The following is a description of a gene set: Mouse Gene Set: GOMF_MOLECULAR_ADAPTOR_ACTIVITY The binding activity of a molecule that brings together two or more molecules through a selective, non-covalent, often stoichiometric interaction, permitting those molecules to function in a coordinated way. species: Mus musculus, and this is the list of marker genes: Shank3, Pramel39-ps, Crtc3, Klhl28, Sla2, Smyd1, Pus1, Stx17, Gosr2, Nanog, Ccdc134, Parp14, Baz2a, Zfp653, Klhl7, Msl3, Med29, Fxr1, Taf1, Ppargc1b, Cdh5, Pramel48, Cul2, Insm2, Cstpp1, Setd3, Cpt1a, Ubqln2, Trim30a, Glyr1, Slc30a9, Golph3, Irs2, Frmd4a, Fbxo42, Ccdc38, Dmap1, mt-Tw, Ppp2r2a, Irak1bp1, Msi1, Cited2, Med15, Vamp1, Ankrd13a, Rraga, Strn3, Atg16l1, Sdr16c5, Eef1a1, Edf1, Pramel56, Camta1 (NCBI Gene Id 75679), Rpa1, Kctd1, Tob2, Ticam1, Lpxn, Zfp541, Daw1, Hipk2, Wipi1, Yap1, Dyrk1a, Tle4, Faf2, mt-Tm, Mms19, Itsn2 (intersectin 2), Klhl11, Ddx1, Appbp2, Racgap1, Kbtbd6, Cux1, Spi1, Cbx7, Med12, Skp2, Pramel30, Sh3bgrl, Spata18, Stap1, Rap2c, Pramel50, Alg14, Trim32, Nme2, Actn3, Klhl8, Lpin1, Ing4, Nlrp4b (NLR family, pyrin domain containing 4B), Sppl2c, Fmr1, Dvl2, Gsdmd, Nsd1, Itsn1, Magi2, Trim13, Rragd, Oog1, Septin14, Foxp3 (forkhead box P3), Mrps36, Trim15, Trim8, mt-Ta, Csnk2b, Med6, Bin1, Cbx2, Ttll12, Bank1, Pramel33, Trim30d, Mki67, Trim30c, Ripk1, Gas2l2, Phf24, Stx1b, Fbxo11, Prima1, Tox3, Fbxo3, Syne2, Slmap, Pramel55, Aip, Uimc1, Tyrobp, Ncoa1, Hdac5, Ercc2, Stat3, Aph1b, Dctn1, Herpud1, Tcf4, Ddx20, Smad7, Hnrnpa2b1, Klhl4, Akap9, H2ax, Kdm1a, Rbfox2, Rybp, Snca (synuclein, alpha), Ncbp1, Septin8 (NCBI Gene Id 20362), Wwc1 (WW, C2 and coiled-coil domain containing 1), Bicd2, Shc1, Akap1, Cbfb, mt-Ts1, Retreg1, Pias2, Ube2l3, Cacybp, Bclaf3, Nipsnap1, Suv39h2, Mark4 (NCBI Gene Id 97378), Tardbp, Dtx3l (NCBI Gene Id 209200), Mier1 (MEIR1 treanscription regulator), Cul3 (cullin 3), Pa2g4, Kbtbd8, Pml, Camta2, Erg28, Iqcb1, Ecpas, Gm3604, Tab2, Pprc1, Sfr1, Ccar1, Fadd, Supt7l, Jchain, Trib3, Tbl1xr1, Ifi204, Ppp1r3c, Prmt2, Zfp1005, Nlrp4e, Fem1al, Hipk1, Tpr, Map2k2 (mitogen-activated protein kinase kinase 2), Usp15, Grb2, Dlgap2, Shb, Sh2d1b1, Psmg2, Mybbp1a, Pramel17, Pramel27, Akap6, Hspa1a, Rere, Anapc7, Vps18, Rab11fip3, Jmy, mt-Tv, Glipr1l1, Tada3, Hcfc2, Phf2, Rad54l2, Hdac4, Nbn, Nupr1, Ap1s2, Tns3, Stx1a, Paxx, Runx1t1, Polk, Kdm5b, Bclaf1, Spin1, Nlrp4c, Hdac1, Pramel47, mt-Ty, Dlgap3, Mical3, Sin3a, Bmal1, Trim12c, Muc1, Men1, Atxn7l3, Golph3l, Morc3, Ager, Hmgb2, Sh2b2, Ccdc124, Brd8, Tdg, Tollip, Pglyrp1, Ythdc2, Trp53, Cdc20, Fcrl2 (Fc receptor like 2), Gab2, mt-Ts2, Sh2d2a, Get1, Klhdc1, Bcl3, Ap1s1, Vamp2, N4bp2l2, Hras, Sap30, Pih1d1, Cebpz, Lpin2, Pef1, Ahdc1, Itga2b, Atg2b, Zzz3, Scimp, Pnkp, Basp1, Btrc, Nolc1, Ctnnb1, mt-Tq, Grb10, Fbxl2, Sfmbt2, Rbp2, Cited4, Sfmbt1, Carm1, Taf12, Gphn, Cdyl2, mt-Tt, Sirt6, Taf7, Kat8 (K(lysine) acetyltransferase 8), Smarcb1, Mrtfb (myocardin related transcription factor B), Sec22b (SEC22 homolog B, vesicle trafficking protein), Fbxw8, Alyreffm5, Ikbkg, Irgm2, Kat6b, Mapk8ip3, Pramel43, Trp53bp1, Myh14, Spen, Keap1, Zfp451, Atp1b2, Arf6, Ap2m1 (NCBI Gene Id 11773), Zfp950, Mlph, Cbfa2t3, Rack1, Wdr59, Ruvbl1 (RuvB-like AAA ATPase 1), Phf10, Slc35d3, Frey1, Notch1, Spaca6, Nkx2-1, Pramex1, Pias4, Dab1, mt-Td, Scrib, Prkaa2, Sarm1, mt-Tn, Brd7, Acss2, Cyren, Ar (androgen receptor), Zfp747l1, Prpf31, Steep1, Exoc7, Smarca2, Zbtb32, Phb1, Pdzd11, Kctd15, Myt1l, Bud31, Fem1c, Irf2bp1, Ivns1abp, Btaf1, Gfi1, Tgfb1i1, Nrg1, Ptpn14, Stx8 (syntaxin 8), Cmtm2a, Taf15, Septin10, Syt1, Vhl, Aimp2, Pclaf, Bcl9, Tada1, Rbbp8, Col4a4, Hnrnpc, Pex6, Kat7, Trim24, Det1, Hdac9, Ap2a2, Trim21 (tripartite motif-containing 21), Rragc, Nelfa, Strn4, Dab2ip, Cdk5rap3, Actn2, Vamp3, Arrb2, Pdcd6, Epb41l3, Cul5, Iqgap1, Hpf1, Nr0b2, Rapsn, Actn1, Ewsr1 (NCBI Gene Id 14030), Sgta, Trip4, Gatad2a, Pramel45, Med26 (NCBI Gene Id 70625), Brd3, Cideb, Hax1, Stx2, Serinc1, Klhl6, Ythdc1, Oog4, Ldlr, Mta1, Cav1, Rbm33, Cul4a, Kdm4a, Ankrd9, Septin2, Bnip1, Med13l, Kat5 (NCBI Gene Id 81601), Mta2, Wbp2nl, Rictor, Pramel21, Insm1, Stxbp1, Hif1an, Klhl12, Dcc, Pcbp2, Ddx17, Ppp2r3a, Mapkap1, Trim12a, Irf2bpl, Gab1, Zmynd8, Nipbl, Rnf20, Id3, Cbfa2t2, Ripk2, Lin28a, Ybx1, Chm, Zfpm1, Ston2 (stonin 2), Sra1, Ilk, Zfpm2, Zfp764l1, Tdrd3, Peli2, Pramel44, Rapgef4, Abi3, Parp10, Alyref2, Rb1, C1d, Crym, Tle6, Ascc1, Traf5, Bhlhe41, Apbb2, Pramel31, Yeats2, Gan (NCBI Gene Id 209239), Noc2l, Traf2, Scai, Fem1a, Bicd1, Tchh, Id2, Ppp4r2, Pramel12, Paqr3, Hmga1, Pramel20, Maged1, Pramel22, Med7, Gnb3, Tada2a, Topbp1, Vim, Sorbs1, Disc1, Chd1l, Lpin3, Alyreffm9, Pramel15, Chd4, mt-Tg, Ippk, Tle1, Homer2, Vgll2, Tbc1d31, Lgals3, Klhl5, Med16, Vti1a, Vcl, Myh9, Tjp2, Jag1, Ski, Kdm3b, Tirap, Gm14443, Klhl25, Dnajb1, Pramel5, Khdrbs1, Mid2, mt-Te, Ksr1, Crtc1, Rufy1, Atf7ip, Mapk8ip1, Ncoa6, Ltbp1, Tle2, Arid5b, Parp9, Prpf6, Mtdh, Taf9, Tcerg1, Zmynd11, Gm13040, Nefh, Crk, Pkn1, Pex26 (peroxisomal biogenesis factor 26), Napb, Eloc, Grb14, Bcl2, Zfp598, Thrap3, Synpo2 (NCBI Gene Id 99735), Col1a2, Mis18a, Sh3rf1, Pcnt, Sun5, Npat, Gnb5, Ctbp2, Syne3, Pramel11, Zfp976, Ddx4, Klhl17, Ifi27l2b, Fgf2, Jade1, Zmiz2, Gabarapl1, Dvl3, Supt3, Mlst8, Zcchc12, Pold3, Lamtor1, Cops2, G3bp2, Nck2, Nck1, Retreg2, Telo2, Fzr1, Hmga2, Ap1m1, Cbx5, Aph1c, Septin5, Igf2bp2, Pcbd1, Ap4e1, Dnajc2, Mier3, Hip1, Midn, Ajuba, Psip1, Dot1l, Stap2, D1Pas1, Fbxo38, Prkn, Ksr2, mt-Tp, Smarca4, Nr3c1, Med12l, Fbxo7, Rcor3, Actn4, Sgtb, Flywch1, Klhl23, Utf1, Cnot1, Tcp10a, Sun2, Pramel49, Pramel14, Brca1, Ruvbl2, Atp1b1, Fnta, Nup153, Nlrp6, Cib1, Arglu1, Liat1, Prkcb, Mdc1, Trim17, Jund, Npm1, Dcaf12, Atg2a, Pias1, Psmc3ip, Zmynd10, G3bp1, Septin11, Sap30l, Klhdc10, Nipsnap2, Hr, Lamp2, Alyreffm8, Zdhhc11, Tcf20, Cidec, Trdn (NCBI Gene Id 76757), Dtl, Tab1, Nab2, Fam81a, Ets1, Fbxw7, Fga, Map2k1, Tax1bp1, Dok2 (docking protein 2), Ddrgk1, Ddx5, Psmg3, Sh2b1, Stx5a, Fscn2, Pramel25, Lmcd1, Smarcd1, Sgk3, Pramel40, Pramel51, Kir3dl1, Sh2d3c, mt-Ti, Capn3, Med8, Dgcr8, Pramel60, Snap47, Pramel19, Letmd1, Traf3ip3, Septin7, Mlip, Cul7, Gps2, Alyreffm11, Med1, Kmt5a, Nfatc2, Jup, mt-Tc, Tfap2a, Rgs14, Lamtor4, Ythdf2, Vps11, Ywhae, Elk1, Nrip1, Uri1, Ccnt1, Tacc1, Mob4, Ehd4, Med24, Med14, Cep63, Zfp1007 (NCBI Gene Id 77200), Stx19, Tnrc6a, Mpp7, Dcaf1, Klhl35, Rbm14, Lmo1, Plcb3, Ldb2, Pramel61, Ythdf3, Kat2b, Ap1s3, Bcor, Nmnat2 (NCBI Gene Id 98444), Dhx9, Apbb1, Niban2, Yaf2, Tcp10b, Mamstr, Smdt1, Cdc42se2, Klhdc2, Adam10, Rbx1, Ccnd1, Kbtbd3, Wnt3a, Mysm1, Calcoco1, Klhl41, Psmg1, Pou2af2, Pex14, Pmf1, Prmt5, Pacsin2, Cys1, Tcerg1l, Med19, Nucks1, Spocd1, Stx16, Sap18, Anapc1, Wnt4, Elane, Hdgf, Asb11, Abi2, Ncoa7, Maml2, Ifnar1, Ssbp3, Trim28, Fan1, Ep300, Baiap2 (brain-specific angiogenesis inhibitor 1-associated protein 2), Dlg1, Cgas, Alyreffm4, Alyref, Pdhx, Faap20, Ing2, Klhdc3, Nlrp4f, Spag4, Paqr4, Gas2l1, Ddit3, Med11, Dlgap4, Fbxl4, Stx3, Jarid2, Ctcf, Tgfbr2, Bcl11a, Vcp, Tpx2, mt-Tf, Rhno1, Hspa8, Kmt2d, Septin1, Sh2b3 (NCBI Gene Id 16923), Pdlim1, Med20, Ezh2, Shank1, Nfkbiz, Cops5, Caprin1, Mak, Draxin, Bnip3, Cdyl, Pramel34, Frs3, Pkp2, Fbxw11, Sike1, Klhl30, Dnajb2, Fscn1, Pramel36 (PRAME like 36), Fiz1, Stx18, Bend6, Fbxo4, Becn1, Dhrs7b, A1cf, Ddx54, Rbx1-ps, Klhl18, Smarcd2, Rb1cc1, Aim2, Nherf1, Cenpj, Zxdc, Ifi27l2a, Tomm70a, Gm45871, Pramel26, Pias3, Kir3dl2, Traf3, Akap13, Napa, Pramel23, Tcf25, Ddx3x, Akirin1, Mideas, Pramel1 (PRAME like 1), Arid5a, Ccin, Ppargc1a, Pramel35, Igf2bp1, Snap91, Hcst, Ezh1, Klhl21, Sod3, Lbr, Fbxo45, Ap1g2, Asxl1, Arrb1, Jmjd1c, Pramel18, Gosr1, Sharpin, Tcp10c, Phf12, Ndc80, Igtp, Mecp2, Cradd, Klhl15, Birc2, Zfp764, Ncoa3, Nlrp4a, Sh3kbp1, Trex2, Klhl20, Htatsf1, Irgq, Tonsl, Psmd4, Nlrp1a, Elob, Gon4l, Irak2, Pptc7, Klhl24, Mphosph8, Ank2, Pde4dip, Hsh2d, Pramel28, Trim38, Usp21, Wnk1, Alyreffm1, Otud4, Ykt6, Chchd3, Kctd17, Zfp366, Setd5, Med17, Nkd2, Cnot9 (NCBI Gene Id 98400), Trim27, Bet1l, Arpc4, Pramel7, Trim55, Fscn3, Kras, Dcaf6, Usp16, Alyreffm3 (NCBI Gene Id 435615), Trim5, Dusp19, Iscu, Ap2a1, mt-Tk, Nefl, Nab1, Lamtor3, Tmf1 (TATA element modulatory factor 1), Thap7, Crtc2, Tsg101, Micall1, Zswim8 (NCBI Gene Id 71906), Stx11, Zfp433, Ston1, Ifi27, Brd1, Pex1, Sub1 (NCBI Gene Id 20024), Eny2, Stx7, Tapbp, Pkm, mt-Tl2, Gm14399, Mrtfa, Rxrb (retinoid X receptor beta), Ncstn, Pramel6, Col4a2, Vti1b, Cnksr1, Cox7a2l, Ctbp1, Rxrg, Igf2bp3, Fhl3, Fis1, Hnrnpu, Pcmtd1, Smarcd3, Ap1g1, E2f1, Tank, Gnb1, Vapa, Ppp2r2d, Lmo2, Kbtbd12, Usp18, Med4, Ankrd13b, Akirin2, Strip1, Cntln, Klhl1, Axin2, Mta3, Napg, Gm14412, Supt20, Pramel13, Fus, Sash1, Tbl1x, Rims2, Irf2bp2, Cnot6, Emilin1, Bet1, Zic3, Zcwpw1, Med13, Dpf2, Mier2, Med22, Trim14, Ldb1, Nsmaf, Drap1, Cd274, Ube2z, Spsb3, Arhgap26, Zfp442, Gmnn (geminin), Brd4, Ark2n, mt-Th, Pramel57, Cnot7, Mapk8ip2, Wdr77, Nr0b1, Akap12, Arrdc4, Oog2, Uxt, Cul1, Gas6, Irf4, Bbs4, Gab3, Brdt, Pramel29, Use1, Eid2, Med27, Snap29, Acp3 (acid phosphatase 3), Alkbh5, Hip1r (NCBI Gene Id 29816), Sertad2, Trerf1, Snw1, Septin3, Kdm2a, Zzef1, Med10, Dlgap1, Kmt2c, Asb1, Map3k10, Zfp354b, Surf6, Fkbp5, Septin4, Arl2bp, Dzip1, Arid3a, Kbtbd2, Ldlrap1, Hsbp1l1, Tial1, C1qbp, Pou2af1 (NCBI Gene Id 18985), Tle5, Hmgb1, Qki, Gm32687, Ipp, Phf8, Nufip1, Sun1, Poldip2, Amfr, Gnb4, Tab3 (TGF-beta activated kinase 1/MAP3K7 binding protein 3), Dab2, H2az2, Alyreffm6, Tradd, Daxx, Id4, Cav2, Per2, Trim30b, Nup98, Eno1b, Tut1, Chd5, Phf13, Pramel41, Ap1m2, Pramel59, Rcor2, Mllt3, Cdca4, Saysd1, Trim62, Hcls1, Fbxo9, Tnnt2, Lat, Stx4a, Pbxip1, Prnp, Park7, Crkl, Insc, Hdac7, Trim6, Ythdf1, Alyreffm10, Gigyf2, Nmnat1, Oog3, Kdm5a, Pwp1, Hcfc1, Wtip, Nlrp12, Lox, Retreg3, Trim37, Pramel46, mt-Tr, Hsbp1, Lamtor5, Ptpn11, Septin9, Srsf3, Sh2d1a, Sertad1, Wwtr1, Limd1, Ankrd1, Septin6, Stx12, Pramel32, Kdm4c, Frs2, Prdm8, Socs7, Ap2s1, Irgm1, Hcn2, Aph1a, Ofd1, Bloc1s6, Atp1b3, Snap23, Klf4, Rnf169, Socs6, Btg2, Apbb3, Phf14, Setd4, Klhl2, Nlrp3, Blnk, Rad17, Abi1, Tsc22d1, Myocd, Pcm1, Kdm7a, Pramel16, Eno1, Pramel24, Sqstm1, Eid1, Kmt2e, Taf6, Wwox, Card9, Zxdb, Nup62, Lmo3 (LIM domain only 3), Apex1, Klhl40, Hdac3, Rcor1, Pramel54, Pramel37, Pramel53, Vapb, Hmga1b, Med21, Med31, Mcur1, Trim11, Ncor1, Lmo4 (LIM domain only 4), Lin7b, Lcor, Rptor, Rbm47, Sp1, Spag9, Ncoa2, Map1a, Ss18, Trabd, Sun3, Klhl38, Stk38, Lin7a, Socs2, Homer1, Ndc1, Vamp9, Tada2b, Nmd3, Id1, Golga5, Trim31, Msl2, Asah1 (NCBI Gene Id 67617), Spsb4, Jazf1, Tle3 (NCBI Gene Id 70332), Spsb2, Klhl10, Irs1, Lin7c, Trim52, Wdr45b (NCBI Gene Id 66840), Mtmr4, Alyreffm7, Trpc4ap, Piwil4, Lrrk2, Dyrk1b, Zfp997, Ticam2, Traf4, Wdr45, Fhl2, Nherf4, Sin3b, Zc3h18, Bmyc, Ddb1, Map2k4, Dcaf13, Pdzk1, Pramel38, Dhx16, Epc1, Tcap, Cdkn1b, Snap25, Stub1, Crebbp, Tle7, Optn, Med9, Septin12, Atn1, Xpc, Med30, Bbln, Skp1, Kdm3a, Mbd2, Sars1, Synm, Nrbf2, Spsb1, Zfp747, Mycbp, Raly, Bcl10, Kat6a, Hyal2, Zfp748, Lrrc75a, Axin1, Akap5, Ncor2, Myd88, Rbpms, Ice1, Klhl22, Lamtor2, Kat2a, Ss18l1, Gnb2, Rab3a, Eid2b, Pir, Nfkb1, Taf5l, Tmem81, Aldob, Morn3, Fhl5, Pex3, Aebp2, Wipi2, Cd53, Zmiz1, Prdx4, Dnmt3b, Gcn1, Sos1, Spata2, Pxn, Maml1, Bag6, Stx6, Dok7, Taf6l, Hipk3, Fem1b, Ambra1, Nkap, Sting1, Cir1, Fbxl19, Atf7ip2, Sirt1, Dync1li1, Cited1, Nfe2l2, Bfar, Wbp2, Prdm16, Wnk3, Ank3, Mavs, Msl1, Kdm2b, Ank1, Rad50, Pick1, Tob1, Cav3, Med18, Becn2, Trim25, Maml3, Epn1, Ubl7, Nos1ap, Klhl3, Ube3a, Xk, Traf6, Vamp8, Bcl9l, Ankrd13d, Klhl29, Myoz1, mt-Tl1, Trrap, Wwc2, Srrt, Hgs, Ccdc62 (coiled-coil domain containing 62), Arrdc1, Naca, Zar1, Sav1, Zfp970, Ecsit, Cdh1, Usp22, Riox2, Traf1, Pou2af3, Atg14, Casp8ap2, Tox2, Pramel42, Kbtbd7, Nlrp1b, Hdgfl2, Asb9, Nherf2, Taf11, Bcorl1, Psmd9, Rrp1b